Given this list of marker genes Kera, Nxt2, Ptprm, Cebpzos, Dmd, Tspan7, Dcun1d3, Znrf2, Gpcpd1, Kcnj13, Zfp46, Fbxo32, Ivns1abp, Majin, Tceanc, Mfsd14a, Klhl20, Igsf11, Gmnc, Phf6, Pcdh7, Sema6a, Slc35d1, Rarb, Ccl11, Cpeb2, Slc24a2, Nfyb, Ctps1, Acsl4, Synpo2, Itgb2, Tbl2, Pcdhb18, Kcnma1, Zc3h12c, Zc3h6, Ptgs2, Dach1, Syt11, Krcc1 (lysine-rich coiled-coil 1), Wac, Orc3, Kpna4, Frmd4b, Rfx7, Zbtb39, Il13ra1, Hs2st1, Clec4b2, Eps8, Repin1, S100b, Sec24a, Slc30a5, Ran, Csmd3, Scrg1, Tmem243, Hgf, Zfand6, Dcun1d1, Sbno1 (strawberry notch 1), Senp6, Klf4, Trpm3, Rtp1, Mat2a, Hook3, Zfp160, Otoa, Tshz3, Tent4b, Stc1, Bmi1, 9330159F19Rik, Tdo2, Mapk8, Gabpa, Arl8b, Dek, Gnpnat1, Rab18, Gnpda2, Nck2, Slc4a4, Vps35, Lair1, Relch, Smarca1, Cdk14, Hsd17b4, Cmtr2, Smap1, Meak7, Card11, Thbs1, Poldip2, here is a description of the gene set: from publication Chen Y, Wang X (PMID 31504780) studied in species Mus musculus Genes predicted to be targets of miRBase v22 microRNA mmu_miR_300_3p in miRDB v6.0 with MirTarget v4 prediction scores > 80 (high confidence targets). Mouse Gene Set: MIR_300_3P